The following is a description of a gene set: from publication Chen Y, Wang X (PMID 31504780) Human Gene Set: MIR330_3P Genes predicted to be targets of miRBase v22 microRNA hsa-miR-330-3p in miRDB v6.0 with MirTarget v4 prediction scores > 80 (high confidence targets). studied in species Homo sapiens, and this is the list of marker genes: RND3, PARP11, NUP58, GPRASP1, ADD3, KCTD18, QNG1, KLF10, TMEM245, FAM72A, ZNF367, RAI2, CTNNB1, FBXL17, FKBP6, AMMECR1, DNM3, ELK4, PPM1B, RIPK2, NAA30, DEFA1B, BMI1, TJP1, GSKIP, ZBTB34, ELK3, SLC4A10, KCNQ3 (NCBI Gene Id 3786), SPTSSB, ARHGAP20, NPTX2, GPAM, DIRAS2, TECPR2, ATAD5, ZNF706 (NCBI Gene Id 51123), MFSD5, DEFA3, POU4F2, TOX (NCBI Gene Id 9760), HNRNPU, SPRYD7, PRKAB2, SUMF1 (NCBI Gene Id 285362), KAT2B, MYBPC1, SNX1, YLPM1, HEATR1, SCP2, MACROD2, RAP2B, RAP1B, SLC25A24, MPZL3, COMMD3-BMI1, KRT82, PROX1, PRRC1, CCPG1, HELZ, TM7SF3, COL6A3, MBNL3, APPL1, RNF126, ERGIC2 (NCBI Gene Id 51290), EBF2, AZIN1 (NCBI Gene Id 51582), MYH3, LIN7C, KNOP1, CYTH3, RCC2, MICU3, BMPR2, ASXL3, FSBP, INO80D, TRPS1, GCN1, TSHZ3, PRKAA2, DLX6 (distal-less homeobox 6, NCBI Gene Id 1750), AK7, GLYR1, ERBB4, BDNF, YTHDC1, PRUNE2, SHC4, CEP170, PPM1L, ATP2B1, DTL, C1orf21, KLHDC9, S100B, C3orf62, FZD3, BFSP1, VGLL3, C2CD2, RBM12, NUP42 (NCBI Gene Id 11097), MYO1C, PABPC1L, GRIA3 (NCBI Gene Id 2892), DPYSL3, NT5DC3, FAM107B, SUB1, SERINC3, METTL1, SH3KBP1, IQCH, DICER1, VSIG10, GDPD1, CMPK1, UBE2G1, FBXW8, TEAD1, ABCA2, KRCC1, TCERG1, ADK, NEFL, C5orf15, RAB8B, VPS13C, CDV3, LTN1, PRDM6, SRPK2, DNAAF2, NBEAL1, PSD3, PRR23C, ELAVL1, MOSMO, LAPTM4B, FCHSD2, RSPO2, NKRF, HIF1A, BCL11B, MAML1, KLHL1, GRM5, PTPRM, THADA, ZKSCAN8, TAF1B, FNTB, SUCO, LAPTM5, MEF2A, TACC3, TRA2A, PDZRN3, THOC3, FOXO1 (NCBI Gene Id 2308), FAM72C, CCN2, GUCY1A2, NAT10, JPH1, GNA13, IP6K2, PDE1A, ABHD17C, ONECUT2, SAXO2, DEFA4, HOXC8, ASB1, RCAN1, LNX2, ACBD5, USP37, SS18L2, L1CAM, AQP9, CREBL2, DEFA1, ARMCX6, GPHN, FAM72D, ZBTB10, PRIM2, EGR4, RMND5A, TNKS, CPNE8, HSPH1, GLS, RGS10, IFNE, ZNF423, DCAF7, FOXJ2, INSL5, IL7R (interleukin 7 receptor), WDR76, SOX6, CXCL5, FAM114A1, LARP4, KSR1, FGFR1, RFWD3, PALM2AKAP2, MLLT10, MINDY2, IGF2BP3, TBL1XR1 (TBL1X/Y related 1), ZFC3H1, MRRF, DIP2B, CFAP54, WDFY3, TSFM (Ts translation elongation factor, mitochondrial), IRX2 (NCBI Gene Id 93965), TRIM2, BTRC, FAM72B, MEOX2, FRK, TMEM178B, DOCK5, ELOVL6, DCK, CCND3, CLDN8, SLAIN1, PURA, KLF9, SLC44A5, PSMA5 (proteasome 20S subunit alpha 5), SOSTDC1, USP13, ADAM22, TNKS2, SALL1, NCOA2, ZNRF3, UBL3, GUCY1A1, SLC10A7, SLCO3A1, HNRNPR, MTDH, CERS6, F12, TRIB2, PDGFD, SIK3, PSG1 (pregnancy specific beta-1-glycoprotein 1), ATP8A2, CSNK1A1, ZNF148, SORL1, IGF1R, CERT1 (ceramide transporter 1), SLCO1C1, MLEC, AMOT, EBF1, EPC1, REST, IL22RA2 (interleukin 22 receptor subunit alpha 2), ANKRD40, MIER3, SEL1L, ACSL6, TARDBP, RO60, PAPOLG, MAP2K5, KITLG, YPEL2, SP4, LRP2BP, ZMAT3, FBXW11, RC3H1, SYK, RAD54B, ZFR, GTF2H1 (general transcription factor IIH subunit 1), FBXW4 (NCBI Gene Id 6468), TMTC1, AGTR2, ITM2C, CLDN18, FRAS1, SLITRK2, DLX1, LSM5, NTN4, ERAP1, SLC39A11, TRAPPC8, MAPK1, ARFGEF2, SAMTOR, LRP8, USP33, KRTAP4-9, SPOCK3, ATP2C1, KCNJ16, CYP7A1, EIF3J, MRPS6, GNRHR, SLITRK4, SLC17A6, TBC1D7, PLS3, SLC24A2, CSNK1G3, AGAP2, MTMR9, EPS8, SLC19A2, SCG3 (secretogranin III), RAP2A, ATL2, METAP2, CDH26, TET2, CREM, CACHD1, JMY, PIK3R3, RUFY2, GIGYF2, APCDD1